Given this list of marker genes FMO2, FMO3, FMO4, FMO1, FMO5, here is a description of the gene set: species: Homo sapiens Human Gene Set: WP_CATALYTIC_CYCLE_OF_MAMMALIAN_FLAVINCONTAINING_MONOOXYGENASES_FMOS Catalytic cycle of mammalian flavin-containing monooxygenases (FMOs)